Given this list of marker genes Snrpd1, Snrpb (NCBI Gene Id 99190), Snrpert, Snrpd2, Prmt5 (protein arginine N-methyltransferase 5), Snrpe, Erhrt-ps, Wdr77, Snrpf, Clns1a, Prmt1, Erh, Snrpd3, Snrpg, here is a description of the gene set: A large (20 S) protein complex that possesses protein arginine methyltransferase activity and modifies specific arginines to dimethylarginines in the arginine- and glycine-rich domains of several spliceosomal Sm proteins, thereby targeting these proteins to the survival of motor neurons (SMN) complex for assembly into small nuclear ribonucleoprotein (snRNP) core particles. Proteins found in the methylosome include the methyltransferase JBP1 (PRMT5), pICln (CLNS1A), MEP50 (WDR77), and unmethylated forms of SM proteins that have RG domains. Mouse Gene Set: GOCC_METHYLOSOME species: Mus musculus